Given this list of marker genes KAZN, KRT20, FURIN, KRT74, TCHH, KRT83, KRT73, SPRR1A, LIPK, KRT36, LCE1C, KRT10, SPINK5, SPRR2B, KRT1, DSC3, LCE2C, KRT39, KRT6B, SPRR2A, IVL, SPINK9, DSG1, PI3, LCE2B, LORICRIN (loricrin cornified envelope precursor protein), KRT71, TGM5, LCE3D, PKP1, KLK5, LCE6A, KRT38, DSC2, LCE3E, KRT82 (NCBI Gene Id 3888), KRT78, KLK13, LCE3C, KRT77, KRT34, KRT37, DSG3, KRT4, KRT76, LELP1, KRT17, KRT6C, KRT16, LIPN, KRT23, JUP, LCE3A, CSTA, DSG4, KRT24, LCE1B, KRT79, LCE3B, KRT75, RPTN, KRT31, SPRR2E, KRT33B, KRT32, KRT3, KRT86, KRT80 (NCBI Gene Id 144501), KRT33A, KLK8, LIPJ, KRT72, ST14, SPRR3, FLG, CELA2A, KRT18, KRT8, PERP, KRT14, KRT26 (NCBI Gene Id 353288), LCE1E, KRT9, EVPL, KLK12, KRT6A, PCSK6, KRT25, KRT5, DSP, KRT28, KRT40, KRT13, LCE2A, KRT19, SPINK6, TGM1, LCE1F, KRT2, CASP14, PPL (NCBI Gene Id 5493), SPRR2F, KRT81, PRSS8, PKP3, KRT35, CAPN1, LCE1A, KLK14, CAPNS1, KRT85, PKP4, LCE2D, KRT15 (NCBI Gene Id 3866), LCE5A, DSC1, LCE4A, KRT27, DSG2, PKP2, SPRR2G, LCE1D, SPRR1B, CDSN, KRT7, KRT84, KRT12, SPRR2D, LIPM (NCBI Gene Id 340654), here is a description of the gene set: Formation of the cornified envelope Human Gene Set: REACTOME_FORMATION_OF_THE_CORNIFIED_ENVELOPE studied in species Homo sapiens